Given this list of marker genes H2AC20, DNMT3B, RBBP4, H2BC9, H2AC18, H2AC7, H3-3A, H4C1, H2AC4, H2BC14, H2AJ, DNMT3A, H2AC6, H2BC12L, H2AB1, H2BC12, H2BC5, H2BC3, H2BC13, H2AX, PRIM1, GSDME, H2BC11, DNMT1 (DNA methyltransferase 1), EZH2 (enhancer of zeste 2 polycomb repressive complex 2 subunit), H2BC4, H3C15, H2BC26, H2AZ2, EED, H2BC1, H2AC14, H3C1, POLA2, SUZ12, H2BC15 (NCBI Gene Id 8341), H2BC21, RBBP7, H2BC17, PRIM2, POLA1, here is a description of the gene set: studied in species Homo sapiens part of: Diseases of programmed cell death Reactome Pathway: Defective pyroptosis Pyroptosis is a form of lytic inflammatory programmed cell death that is mediated by the pore‑forming gasdermins (GSDMs) (Shi J et al. 2017) to stimulate immune responses through the release of pro‑inflammatory interleukin (IL)‑1β, IL‑18 (mainly in GSDMD-mediated pyroptosis) as well as danger signals such as adenosine triphosphate (ATP) or high mobility group protein B1 (HMGB1). Pyroptosis protects the host from microbial infection but can also lead to pathological inflammation if overactivated or dysregulated. During infections, the excessive production of cytokines can lead to a cytokine storm, which is associated with acute respiratory distress syndrome (ARDS) and systemic inflammatory response syndrome (SIRS). Pyroptosis has a close but complicated relationship to tumorigenesis, affected by tissue type and genetic background. Pyroptosis can trigger potent antitumor immune responses or serve as an effector mechanism in antitumor immunity (Wang Q et al. 2020; Zhou Z et al. 2020; Zhang Z et al. 2020). It also shows epigenetic inactivation of GSDME due to hypermethylation of the GSDME promoter region (Akino K et al. 2007; Kim MS et al. 2008a,b; Croes L et al. 2017, 2018; Ibrahim J et al. 2019). Aberrant promoter methylation is considered to be a hallmark of cancer (Ehrlich M et al. 2002; Dong Y et al. 2014; Lam K et al. 2016; Croes L et al. 2018). Treatment with the DNA methyltransferase inhibitor decitabine (5‑aza‑2'‑deoxycytidine or DAC) may elevate GSDME expression in certain cancer cells (Akino K et al. 2007; Fujikane T et al. 2009; Wang Y et al. 2017).